Given this list of marker genes Pnpo, here is a description of the gene set: electronically inferred by orthology from the curated human pathway Reactome Pathway: Vitamin B6 activation to pyridoxal phosphate studied in species Mus musculus part of: Metabolism of water-soluble vitamins and cofactors This event has been computationally inferred from an event that has been demonstrated in another species.<p>The inference is based on the homology mapping from PANTHER. Briefly, reactions for which all involved PhysicalEntities (in input, output and catalyst) have a mapped orthologue/paralogue (for complexes at least 75% of components must have a mapping) are inferred to the other species.